Given this list of marker genes IFT140, TULP1, RBP4, BBS4, PRPF31, SLC7A14, MECR, IFT88, LZTFL1, MKS1, MFN2, RAX2, MT-ND5, HESX1, PDE6C, MT-CO3, POC1B, RLBP1, PODXL, AGBL5, IMPG2, FGF14, CNGA3, WDR11, TIMM8A, PITPNM3, PDXK, ROM1, PROK2, TMEM126A, DNAJC6, TACR3, GNAT2, RPGRIP1, DHDDS, USH2A, REEP6, IFT172 (NCBI Gene Id 26160), IDH3A, ARHGEF18, FEZF1, FGF8, PRPF6, IFT27, SAG, NDUFS2, FGF17, DRAM2, TRPM1, CEP290, PDE6B, CABP4, BBS7, FGFR1, FOXC1, TRIM44, MT-ND2, RBP3, TOPORS, CNGA1, SNCA, CACNA1F, RP9, RDH12, SCLT1, RP1, MT-ND4, BBS1, BBS5, SEMA3A, VPS13C, RPE65, PDE6H, ACO2, CNGB3, PRPF3, OFD1, CFAP410 (NCBI Gene Id 755), MTRFR, ALDH3A2, NYX, ZNF513, OPN1LW, TRIM32, LRRK2, NBAS, BBS9, SPRY4, BBIP1, GNB3, BEST1, ARL6, PINK1, NR2E3, MT-ATP6, GNAT1, CHM, SPATA7, TK2, NDNF, AFG3L2, OPA1, PRPF4, MT-CYB, CNNM4, PRPH2, HGSNAT, CNGB1, MFSD8, UNC119, CACNA2D4 (calcium voltage-gated channel auxiliary subunit alpha2delta 4), ZNF408, PCARE (photoreceptor cilium actin regulator), ELOVL4, PARK7, IMPG1, RAB28, MT-ND6, BBS2, OPN1SW, AHR, SLC24A1, KLHL7, POMGNT1, RPGR, GUCA1A, GUCY2D, FAM161A, IDH3B, CLRN1, OPA3, PDE6A (phosphodiesterase 6A), TTLL5, C1QTNF5, TUB, MT-CO1, MT-ND1, OPN1MW, MCAT, RHO, WDPCP (WD repeat containing planar cell polarity effector), FLRT3, POLG, DCC, ARL3 (ADP ribosylation factor like GTPase 3), SNRNP200, HS6ST1, MAK, PRCD, MORC2, MERTK, LCA5, FA2H, HTRA2, AIPL1, FSCN2, MKKS, NRL, MT-ND4L, TTC8, PROM1, IL17RD, CEP19, BBS12, CCDC141, KIZ, NPHP1, LRAT, IMPDH1, PDE6G, CDHR1, TLCD3B, UCHL1, ABCA4, AHI1, PROKR2, CYP4V2, KIAA1549, DUSP6, RTN4IP1, PAX6, GUCA1B, RP2, IFT74, NEK2, CEP78, CA4, SDCCAG8, RGR, RIMS1, PRKN, CERKL, GRM6, RP1L1, LRIT3, ATF6, SOX10, CFAP418, MTTP, SYNJ1, EYS, GPR179, ARL2BP, CRB1, SEMA4A (NCBI Gene Id 64218), GRK1, ANOS1, CC2D2A, SCAPER, NMNAT1, CRX, PRPF8, DNM1L (NCBI Gene Id 692222), BBS10, DHX38, DNAJC30, CHD7, ADAM9, here is a description of the gene set: An anomaly in the ability to discriminate between or recognize colors. species: Homo sapiens Human Gene Set: HP_COLOR_VISION_DEFECT Color vision defect